Given this list of marker genes CCM2, EEIG2, BDP1, NSL1, TM4SF20, ANKS1B, CDH17, CIPC, GABPA (GA binding protein transcription factor subunit alpha), OTUD6B, BNC2, HS3ST4 (NCBI Gene Id 9951), ATP8A2, PALD1, TCF3, EFCAB11, FOXJ2, FFAR2, SNRNP27, TXNIP, SEC24B, RUFY3, ERLIN1, HK2, CIAO2A, PITPNB, AHCYL1, UBTD1, TRAF3, RAB5A, TENT5A, CCNT2, SEMA4B, OSBPL3, EIF2S2, CALB1, PAPPA (pappalysin 1), BMP2, PTPN12, MTX3, MASP1, NAMPT, EMC3, NPAS3, NFYB, PTGFR, RECK, RRAS2 (NCBI Gene Id 22800), PRX, PDS5A, DHX9 (DExH-box helicase 9), TBC1D5, SGMS1, ZNF12, ZFX, GPR35, RNF222, COMMD8, MEA1 (male-enhanced antigen 1), MBLAC2, SPIN1, ASXL3, ZMYND8, ING2, HHEX, WDR33, TNPO1, HNF1B, NR2C2, CEMIP, HIC2, PPIL3, POU2AF2, GTF3C2, ZEB1, TEX30, XPO6, ZNF322, PNMA1, RAB1A, PKIA, RSPRY1, here is a description of the gene set: Human Gene Set: MIR301A_5P Genes predicted to be targets of miRBase v22 microRNA hsa-miR-301a-5p in miRDB v6.0 with MirTarget v4 prediction scores > 80 (high confidence targets). species: Homo sapiens from publication Chen Y, Wang X (PMID 31504780)